Given this list of marker genes CYP2E1, FAM83C, DCUN1D3, ADAMTSL3, GMNC, CACNA1A, GLYATL1, CCDC136, EIF2AK3, CACNA1G, TBATA, AFAP1, C2orf15, FSIP1, CLU, CHCT1, COL7A1, CBY3, GPR3, COL6A6, LINC01949, FRAT2, BBS1, ENTPD3, ARIH1, CR2 (complement C3d receptor 2), CYMP (chymosin, pseudogene), CABP2, FOXP2, GPR39, FLYWCH2, BOLA1, ENTPD2, ARSJ, EML3, CYSLTR2, DHRS9, BCS1L, CCDC97, CAMSAP2, BMS1P1, MYRF-AS1, CITED4, AMH, TMEM263, GEMIN4, CASKIN2, GATC, EIF2AK2, GPBAR1, GNS, GFRA1, CSTA, CD8B, ARHGAP5, GPR65, ASB4, DDX18, OGFOD3, ASMTL-AS1, FGF23, CXCL16, CD46, NELFB, EMID1, ADCY9, ALX1, SCP2D1, CPLX2, ASB15, LINC03040, CALCA, ACOT6, GAS6-DT, DAAM2, DYNC1I1, CAMK1D, FNDC8, LINC00951, DLX1, ARPIN, DUS4L, FXYD5, CCDC33, HEPACAM2, COPG1, DOCK6, PRR29, HELZ, LINC01588, EYA3, ALKBH7, BTAF1, CMTM5, C10orf53, CUBN, ENPP3, FBXW9, SOWAHA, GPC2 (glypican 2), AGXT, ARL4A, GJB3, ANK1, DLL3, CXCL14, DNAH17 (NCBI Gene Id 8632), GTF2IRD1, EFR3A, FIBIN, CPNE4, C2CD2, GABARAPL3, CHRNB2, C16orf82 (NCBI Gene Id 162083), ADAT3, C10orf88, CEACAM19, COL10A1, GPR137, EOMES, ARHGAP35, FDCSP, CYBB, BDNF, ANKMY1, CGA, FIBCD1, FAM47A, ANKRD45, CHCHD7, RHNO1, LY6S-AS1, GSTM4, CC2D1B (coiled-coil and C2 domain containing 1B), RMDN3, AVPR1A, CLEC14A, FAM111B, CXXC1P1, BPI, CCDC180, DGCR5, PXYLP1, LINC02880, F13A1, SMG8, EXOC2, SAXO4, DMTN, CCDC152, FAAP100, GUCY1A1, CHD9 (NCBI Gene Id 80205), DUSP14, GPC4 (NCBI Gene Id 2239), CD40LG, GALNT9, PAXBP1-AS1, COX7A1, FKRP, AMPD2, ARHGEF19, ATXN3L, GUF1, EFNB1, BOLA3, BAALC-AS2, CEP164, CNPY1, C4orf36, FAM110D, AP4B1 (adaptor related protein complex 4 subunit beta 1), PAGR1, INHBE, ALPK1, EPM2AIP1, GPAT4, GRIN3B, ZNF736, DOK5, GASK1B (NCBI Gene Id 83936), BEND4, BBOX1, HEPACAM, TEX38, ABCC3, CHAF1A, KLHL30-AS1, GIMAP8, ZBTB7C-AS2, HEATR1, ETV6, FBRSL1, ACVR2A, here is a description of the gene set: Genes up-regulated in comparison of non-suppressive T cells versus activated regulatory T cell (Treg). Gene expression profiles of subsets of CD4+ T cells according to their expression of FoxP3 and CD45RA were compared. FoxP3 is a key transcription factor for the development and function of natural CD4+ regulatory T cells (Tregs). Here we show that human FoxP3+CD4+ T cells are composed of three phenotypically and functionally distinct subpopulations: CD45RA+FoxP3low resting Tregs (rTregs) and CD45RA-FoxP3high activated Tregs (aTregs), both of which are suppressive in vitro, and cytokine-secreting CD45RA-FoxP3low non-suppressive T cells. The proportion of the three subpopulations characteristically altered in cord blood, aged individuals, and patients with immunological diseases. Terminally differentiated aTregs rapidly die while rTregs proliferate and convert into aTregs in vitro and in vivo as shown by the transfer of rTregs into NOD-scid-common gamma-chain-knockout mice and by TCR sequence-based T cell clonotype tracing in peripheral blood of normal individuals. Taken together, the dissection of FoxP3+ cells into subsets enables one to analyze Treg differentiation dynamics and interactions in normal and disease states, and to control immune responses through manipulating particular FoxP3+ subpopulations. from publication Miyara M, Yoshioka Y, Kitoh A, Shima T, Wing K, Niwa A, Parizot C, Taflin C, Heike T, Valeyre D, Mathian A, Nakahata T, Yamaguchi T, Nomura T, Ono M, Amoura Z, Gorochov G, Sakaguchi S (PMID 19464196) studied in species Homo sapiens Human Gene Set: GSE15659_NONSUPPRESSIVE_TCELL_VS_ACTIVATED_TREG_UP